The following is a description of a gene set: species: Homo sapiens A viral genome replication where the template is single-stranded RNA (ssRNA), and which proceeds via a double stranded DNA (dsDNA) intermediate molecule. Viral genomic RNA is first reverse transcribed into dsDNA, which integrates into the host chromosomal DNA, where it is transcribed by host RNA polymerase II. Human Gene Set: GOBP_SINGLE_STRANDED_VIRAL_RNA_REPLICATION_VIA_DOUBLE_STRANDED_DNA_INTERMEDIATE, and this is the list of marker genes: TRIM28, TOP2B, AICDA, INPP5K, APOBEC3C, CXCL8, APOBEC3B, TOP2A, APOBEC3G (apolipoprotein B mRNA editing enzyme catalytic subunit 3G), SMARCB1, HMGA2, APOBEC3F, APOBEC3A (NCBI Gene Id 91577), APOBEC3D, APOBEC3H